The following is a description of a gene set: Abnormality of the biliary system Human Gene Set: HP_ABNORMALITY_OF_THE_BILIARY_SYSTEM An abnormality of the biliary system. studied in species Homo sapiens, and this is the list of marker genes: IL12RB1 (NCBI Gene Id 3594), SAMHD1, METTL27, NPC1, PARS2, F5 (coagulation factor V), SPTB, LHX3, MST1, PIGG, DHCR7, SUPT16H, NELFA, TSHR, ALAS2, UROS, ABCD3, HGD, ARVCF, SEC24C, CDIN1, COG7, STXBP2, SLC30A10, ADAR, RPGRIP1L, CASK, VPS4A, TCTN3, FLI1, TRAF3IP1, RREB1, APC2, RFX6, SLC26A4, ELN, FCGR2A, BCS1L, DMPK, MAP2K1, UFD1, FOCAD, LMNA (NCBI Gene Id 7816), AKR1D1, ALDOA, SMPD1, REL, ALG6, TNFSF15, GH1, INSR, BMP6, WDR19, PRKAR1A, PEPD, FCGR3B, CIITA, SLC10A1, UBR1, AMACR, SLC5A5, SEC23B, MPV17, AP1B1, TJP2, LPL, SAA1, UNC45A, MKS1, ITPR1, IFIH1, NKX2-1, DNAJC30, RNASEH2C, TRMU, TRHR, STX11, POMC, MED25, PKD2, GPI (glucose-6-phosphate isomerase), CYP27A1, GNB2, NCF1, EPCAM, B9D2, ATP6AP2, SPINK1, CASR, GALE, DUOXA2, DCDC2, PHKG2, FARSB, ITCH, JAG1, GNE (glucosamine (UDP-N-acetyl)-2-epimerase/N-acetylmannosamine kinase), TMEM67, KRT18, STK11, LIMK1, RNU4ATAC, IL2RG, TTC7A, NKX2-5, ATP7A, HYOU1, MARS1, LHX4, TBX1, CEP83, KIF23, ASAH1, GYPC, COX4I2, EPB42, PYGL, ARL13B, SCNN1B, OCLN (occludin), AP1S1, SERPINA1, PKLR, DGUOK (deoxyguanosine kinase), GPR101, IER3IP1, LSM11 (NCBI Gene Id 134353), PEX11B, USP9X, PRSS1, GALT, CCDC28B, FKBP6 (NCBI Gene Id 8468), ADK, PGM1, CEP290, TULP3, PEX10, PEX1 (NCBI Gene Id 7788), HBB, LYST, SMAD4, STX1A, KMT2E, SPTBN1, WDR35, ABCC2, ALDOB, SCO2, ZNF699, BAZ1B, CDKN1B, NR1H4, TBX19 (T-box transcription factor 19), NSD2, KDM5C, RHD, NPC2, CPA1, HBG2, TREX1, PRKCSH, INTU, ARG1, IL12A, GCGR, CTBP1, HSD17B4, IRF5, GLIS3, CFTR, ATP11C, CLIP2, ARSA, SLC2A1, DNASE2, EIF4H, POLG2, BAAT, PALLD, CCDC47, DZIP1L, NBAS, FUCA1, TGFB1, RNASEH2B, PEX19, FGFRL1, SCNN1G, GATA6, PIGA, AIRE, EPB41, CDAN1, TNPO3, TRPV6, RFX5, SLC4A1 (NCBI Gene Id 8158), SCNN1A, GNAS, FOXE1, ETFA, FH, RFC2, NAA10, NRAS, PRF1, CA5A, AGR2, IYD, RAB27A, PEX14, SLC16A2, ERCC4, IFT122, EIF2AK3, VPS50, IARS1, HADHB, SLC51A (solute carrier family 51 member A), PIEZO1, SPOP, GALK1, BUD23, CYP7B1, INPP5E, MECP2, KCNN4, LRP5, PFKM (NCBI Gene Id 5215), EARS2, ROS1, LYN, NEUROG3, RBCK1, CD40LG, GTF2I, JMJD1C, PEX6, PAX8, IGHG2, VPS37D (NCBI Gene Id 171020), RHAG, DHFR, MICOS13, SLCO1B3, IL21R, KYNU, COG6, PEX13, PTPN3, NPHP3, COMT (catechol-O-methyltransferase), BBS1, CPLX1, RINT1, HTRA2, NSD1, HOXD13 (homeobox D13), ESCO2, VPS33B, ZFYVE19, TCF4, PI4KA, SHPK, SLC25A13, TMEM270, BRAF, KMT2D, GTF2IRD1, LMBRD1, CCDC115, HIRA, RFXANK, PERCC1, RFXAP, FADD, TMEM216, XIAP, HMGCL, TSHB, LBR (lamin B receptor), GP1BB, GCLC, ETFDH, IFT56, ABCD1, SC5D, SLC51B, CYP7A1, FOXF1, ABCG8, ETFB, ABCB11, B3GLCT, SPTA1 (NCBI Gene Id 6708), IFT172, PEX26, ACADVL, GFM1 (G elongation factor mitochondrial 1), LONP1, SEC63, KIF12 (NCBI Gene Id 113220), CTCF, RHCE, MTR, TPI1, FGA, DEF6, FECH, ATP6AP1, AIP, TFE3, VIPAS39, CLDN1, CNOT1, DPAGT1, HESX1, SON, IGKC, GALM, PEX16, PRPS1, JAK2, ATP8B1, SLC37A4 (NCBI Gene Id 84965), PNPLA2, KRAS, PALB2, PRSS2, IL18BP, ANK1, HSD3B7, UQCRFS1, BCAP31, ABCB4, MMACHC, DUOX2, CTRC, POT1, NEK8, TFAM, GPR35, TG, SKIC3, ALG8, PEX2, SLC44A1, PKHD1, BRCA1, PROP1, LETM1, SP110, BLVRA, G6PD, ATP7B, TBL2, MYO5B, CDKN2A, GBA1, CC2D2A, HFE, SCARB2, POU2AF1, GTF2IRD2, TP53, HADHA (hydroxyacyl-CoA dehydrogenase trifunctional multienzyme complex subunit alpha), TPO, LIPA, SLCO1B1, MED12, HNF1B, IL36RN, SEMA4D, RNF43, PSAP, KIF3B, RNASEH2A, YARS1, UGT1A1, ASXL1, ANKS6, MRPL39, MMEL1, POU1F1, SPIB, PHKA2, DOCK8, ARL6, PEX12, ADAMTS13, NOTCH2, HK1, CALR, CPOX, PEX3, BRCA2, STX5, ZIC3, PCSK1, PEX5, SLC2A2, RABL3, POLG, RNU7-1, USP53, GLRX5, UNC13D (NCBI Gene Id 201294), IFT140